Given this list of marker genes MPP1, UBE2I, ERGIC2, PLEKHN1, THRAP3, AKR1B10, ITGA4, CDK5RAP2, SMAGP, IRF8, HDAC6, ATP1B2, TMEM38B (NCBI Gene Id 55151), FNBP4 (formin binding protein 4), SECISBP2, CD14, FGL2, FBRS, BCDIN3D, CYBB, TMEM179B, AGR3, PLCZ1, QSER1, TLE2, RNF167, NIT1, KMT2E, GALC, COG6, CSF2RA, N4BP2L1, DDX17 (NCBI Gene Id 10521, DEAD-box helicase 17), CD82 (NCBI Gene Id 8052), BAZ2A, NOTCH1, NEU3, CMIP, LAMB1, STARD3 (NCBI Gene Id 10948), ZBP1, ZFAND2A, ZEB1, SPEN, SLC41A2, HTATIP2, ATP6V1C1, MOB1A, TTC39C, AIG1, TRIP12, POLR1C, OAS2, RBM43, SKI, ATP2C1, SLC28A2 (NCBI Gene Id 9153), ABR, POU3F3, PARD6A, MCMBP, KIN, MTMR7, THOC1, IQSEC1 (IQ motif and Sec7 domain ArfGEF 1), BNIP2, DPM2, WBP2, VPREB1 (V-set pre-B cell surrogate light chain 1), DPCD, ARC, SPEG, SHC1, HPS4, MARK4, PRKG2, SMOX, UBXN8, FER, CMTR1, IFI30 (IFI30 lysosomal thiol reductase), SLC2A5, TNFRSF1B, SNX2, PCYOX1, RBM47, POLR1D, CCL5, STXBP3, CD47, TMEM19, TPRA1, G3BP2, ASB3, HSD17B13, SMC5, ARF4, RPE, ENG, ETV3, GDI1, PPP1R2P1, MMP14, SALL3, TNRC6A, TRIP11, SLC39A4, SLC30A7, ANXA9, PNRC1, C5orf15, EMC7, SETDB1, ZNF574, RBM7, TIMM10B (translocase of inner mitochondrial membrane 10B), PRKCH, CTTNBP2NL, POLB (DNA polymerase beta), SPTLC1, DDHD1, RCE1, CAPZA1, RABIF, CHIC2, CLEC4E, PLEKHA3, KATNA1, NIPAL2, GNG11, KL, EPSTI1, ELOF1, RABGGTB, MGAT2, C1orf52, TMEM131L, MSL1, MFAP1, STXBP1, PRPF38A, STARD3NL, GK2, MED20, CD200, SNX14, TMUB2, NAB1, COG8, EDEM3, SYF2, DRAM2, LTC4S, SLC29A3, KEAP1, CCDC127, PDK3, ART3, OSBPL11, CLEC5A, CDK20, PPP2R5A, PEX11A, ANXA5, ARPC1A, OAZ2, NAA40, PGD, MLLT10, CNP, PSME3IP1, SELENOM, PSME3, MSN, TRMT1L (NCBI Gene Id 81627), FBXW11, TUT1, IFT57, KLRK1, GDE1, MBP, PTPN6, ATP10A, PRPS2, KDM1A, SNX10, MAN1A2, RIPK2, PON3, SLC5A3, DCAKD, ADAT1, PDCL, PRDX1, CXCR4, GUCD1, ZBTB20, APBB2 (amyloid beta precursor protein binding family B member 2), NAA30, here is a description of the gene set: species: Homo sapiens from publication Amit I, Garber M, Chevrier N, Leite AP, Donner Y, Eisenhaure T, Guttman M, Grenier JK, Li W, Zuk O, Schubert LA, Birditt B, Shay T, Goren A, Zhang X, Smith Z, Deering R, McDonald RC, Cabili M, Bernstein BE, Rinn JL, Meissner A, Root DE, Hacohen N, Regev A (PMID 19729616) Genes down-regulated in comparison of dendritic cells (DC) stimulated with poly(I:C) (TLR3 agonist) at 0.5 h versus those stimulated at 24 h. mouse primary BMDCs were stimulated with tlr ligands and gene expression changes were profiled on Affymetrix arrays Human Gene Set: GSE17721_0.5H_VS_24H_POLYIC_BMDC_DN